Given this list of marker genes VPS37B, SDHB, FBXO40, KCNB1, PRAME, MMP25, TCIRG1, BAZ2B, GPSM3, ZCCHC4, GAD2, YIF1B, SCAF11, FAM53C, PLXNA2, RAC2, SIPA1L1, OR10H2, CCNI, PIAS1, TRAPPC14, LRRFIP1 (NCBI Gene Id 9208), REG1B, WDR26, SERP1, KRT23, TRIM8, CTDSP2, FOSL2, SORBS1 (sorbin and SH3 domain containing 1), MAPK1, PRKD1, S100A14, FBRS, OR12D2, PARM1, SETD2, MYO16, TCTA, MARF1, TCF20, ARHGAP45, RUBCNL, CCN4, RUFY1, CX3CL1, APAF1, SLC12A6, AGTPBP1, LINC00115, CUL4B (NCBI Gene Id 8450), GABRA3, RAB5IF, NHLH2, PDGFD, RYK, IFIT2, ASAP1, USP4, MCL1, SERPINA3, ADGRE2, TLE3, TENT5A, TRPC4AP, SECTM1, SMARCD3, SP3P, IVNS1ABP, ATP6V0B, P2RY14, CCN2, ACAP2, NPPC, NPR3, NSFL1C, RIPOR1, MARK3, GMIP, PISD, ARMC7, LST1, SEC24B, RNF141, SLC22A14, MIR22HG, CD53 (CD53 molecule), SNRK, KCNK7, KDM5A, FCAR, HEY1, TFAP2C, PAK1, TMCC1, CDK20, TACR3, ZNF446, LTBP2 (NCBI Gene Id 83981), KATNBL1, SMIM27, VCL, ACOX1, TRDMT1, FMO1, FLRT1, STC1, MPPE1, DSG1, SARAF, CXCL6, RAB7A, SLC28A2, OTULINL, IMPDH1, SQOR, PFKFB3, ARHGDIB, VNN1, ZDHHC7, PFKFB2, PDLIM2, GRIA2, KLF4, TRANK1, ALS2CL, SEMA4A, TSG101, LOXL2, PSG4, RNF44, DPP8, ERBB2, SLA, CA12, MINDY1, ZDHHC17, MSRA, LRRC2, EXD3, ITGB2, B3GAT1, S100P, IL1R1, IFNAR2, HLX, DCUN1D2, MBD5, SLC19A4P, ARHGAP25, CAPZA1, RNPEPL1, SCML1, COL1A1, ZNF394, BTN3A1, MARCHF7, GRIK5, BTBD7, HNF4A, JADE1, DOCK4, HR, HOXA5, NRBF2, APLP2, SLC34A2 (solute carrier family 34 member 2), MED25 (NCBI Gene Id 81857), L1CAM, SPATA6, TLR6, CDC14A, MIR9-1HG, BIN2, PLAU, GUCY2D, EXOC1, NCK2, SLC30A3, RAB2A, LIMK2, CYTH4, ARAP1, RAF1, MCF2, ARHGEF4, UBE2D3, KIF5A, SNX13, RAB33B (NCBI Gene Id 83452), MXD1, PADI4, MVK, ESM1 (endothelial cell specific molecule 1), LRRC37BP1, CATSPERZ, DNAJC3, here is a description of the gene set: Genes up-regulated in comparison of neutrophils versus Th1 cells. studied in species Homo sapiens In the present study we used Affymetrix oligonucleotide microarrays to produce gene transcription profiles for the major leukocyte types in humans. This comprehensive dataset enabled us to not only establish which genes were expressed in each leukocyte type, but also which genes were expressed in each subset after activation. The used of a comprehensive dataset of gene profiles from all the major human leukocyte subsets enabled a novel and powerful means for identification of genes associated with single leukocyte subsets, or different immune paradigms. from publication Jeffrey KL, Brummer T, Rolph MS, Liu SM, Callejas NA, Grumont RJ, Gillieron C, Mackay F, Grey S, Camps M, Rommel C, Gerondakis SD, Mackay CR (PMID 16474395) Human Gene Set: GSE3982_NEUTROPHIL_VS_TH1_UP